The following is a description of a gene set: studied in species Mus musculus The directed movement of the nucleus to a specific location within a cell. Mouse Gene Set: GOBP_NUCLEAR_MIGRATION, and this is the list of marker genes: Nherf1, Pax6, Fhod1, Hhex, Clmn, Dync1h1, Cep120, Pafah1b1, Cdc42bpa, Slit1, Fbxw11, Tacc1, Ptk2, Kif1a, Tacc3, Sun2, Pcm1, Sun1, Lmnb1, Dctn1, Lmna, Trim58, Syne2 (NCBI Gene Id 630548), Tmem201, Myh10, Syne3, Cdc42, Ntn1, Dock7, Lmnb2, Hook3, Tacc2, Nudc (nudC nuclear distribution protein), Syne1